Given this list of marker genes TNFRSF18, MED30, PGM3, BANK1, PAN2, KCNJ3 (potassium inwardly rectifying channel subfamily J member 3), MDK, KAT6B, GFOD3P, JMJD8, PARVG, TNKS, MATN1-AS1, AHCYL1, KLHL28, ALOX5AP, GPR155, LIN52, CASK, CLCC1, FCER2, FADS3, RBL2, MCPH1, LEPROT, NUDT21, ACSL1, AKR7A2, PHTF1, RBL1, TMSB4X, TOGARAM1, C1orf52, TBL1X, ALDH2, ALDH6A1, QKI, APOLD1, GCH1, SPAG16, SMARCA5, SLC17A9, GPR88, RASSF3, NSD3, DLEU2, PMS1, FAM120C, IP6K1, KIF21A, PATZ1, RTL6, METTL25, SIVA1, CBLB, ENSG00000284634, EDRF1, PLD4, SLC38A2, CHPT1, CNOT7, DCK, TBCK, NASP, SELENOF, WAC, MACROD2 (mono-ADP ribosylhydrolase 2), MED6 (NCBI Gene Id 10001), ARHGAP18, ACTR3, ATP2B1, MAGEF1, RFC1, BTG1 (BTG anti-proliferation factor 1), PRMT6, B3GALT6, ZFP90, IL10RA, KCNMB2, BORCS8-MEF2B, BNIP3L, ZNF320, P2RX1, ERO1B, FERMT2, ATG14 (NCBI Gene Id 22863), PNMA1, ZNF84, CPEB3, STAM2, SGK3, ANAPC16, SLC8A1, here is a description of the gene set: Genes commonly up-regulated in CD-1 and CD-2 clusters of multiple myeloma samples and which were higher expressed in the CD-1 group. studied in species Homo sapiens from publication Zhan F, Huang Y, Colla S, Stewart JP, Hanamura I, Gupta S, Epstein J, Yaccoby S, Sawyer J, Burington B, Anaissie E, Hollmig K, Pineda-Roman M, Tricot G, van Rhee F, Walker R, Zangari M, Crowley J, Barlogie B, Shaughnessy JD Jr (PMID 16728703) Human Gene Set: ZHAN_MULTIPLE_MYELOMA_CD1_AND_CD2_UP To better define the molecular basis of multiple myeloma (MM), we performed unsupervised hierarchic clustering of mRNA expression profiles in CD138-enriched plasma cells from 414 newly diagnosed patients who went on to receive high-dose therapy and tandem stem cell transplants. Seven disease subtypes were validated that were strongly influenced by known genetic lesions, such as c-MAF- and MAFB-, CCND1- and CCND3-, and MMSET-activating translocations and hyperdiploidy. Indicative of the deregulation of common pathways by gene orthologs, common gene signatures were observed in cases with c-MAF and MAFB activation and CCND1 and CCND3 activation, the latter consisting of 2 subgroups, one characterized by expression of the early B-cell markers CD20 and PAX5. A low incidence of focal bone disease distinguished one and increased expression of proliferation-associated genes of another novel subgroup. Comprising varying fractions of each of the other 6 subgroups, the proliferation subgroup dominated at relapse, suggesting that this signature is linked to disease progression. Proliferation and MMSET-spike groups were characterized by significant overexpression of genes mapping to chromosome 1q, and both exhibited a poor prognosis relative to the other groups. A subset of cases with a predominating myeloid gene expression signature, excluded from the profiling analyses, had more favorable baseline characteristics and superior prognosis to those lacking this signature.